Given this list of marker genes CCND1, E2F3, CDKN1A, CDK6, RB1, CCND2, CCND3, MDM2 (NCBI Gene Id 84825), E2F2, CDK4, E2F1, TP53, here is a description of the gene set: Human Gene Set: KEGG_MEDICUS_VARIANT_AMPLIFIED_MDM2_TO_P21_CELL_CYCLE_G1_S Pathway Definition from KEGG: MDM2* -| TP53 => CDKN1A -| (CCND+CDK4/6) -> RB1 // E2F Amplified MDM2 to p21-cell cycle G1/S. Pathway ID: N00068. Pathway type: Variant. Pathway class: nt06273 Glioma. studied in species Homo sapiens